The following is a description of a gene set: Enables the transfer of a polyol from one side of a membrane to the other. A polyol is any polyhydric alcohol. studied in species Homo sapiens Human Gene Set: GOMF_POLYOL_TRANSMEMBRANE_TRANSPORTER_ACTIVITY, and this is the list of marker genes: AQP10, AQP7, AQP9, AQP1, AQP7B, AQP11, SLC5A11, SLC5A1, SLC5A3, SLC2A13, AQP3 (aquaporin 3 (Gill blood group)), AQP2